The following is a description of a gene set: species: Mus musculus Genes predicted to be targets of miRBase v22 microRNA mmu_miR_6951_3p in miRDB v6.0 with MirTarget v4 prediction scores > 80 (high confidence targets). Mouse Gene Set: MIR_6951_3P from publication Chen Y, Wang X (PMID 31504780), and this is the list of marker genes: Syndig1l, Ythdf2, Kcnf1, Samd4, Mtss1, Cmtm5, Mark2, Tdrd3, Gab2, Bdnf, Galnt1, Angptl1, Rgs5, Pnma2, Sh3bp5, Pde4b, Mcc, Mllt3, Stxbp5l, Csgalnact2, Polr1g, Tmem39b, Slitrk1, Gtf2a1, Nrip3, Ccne2, Gnb4, Irx5, Ing1, Tab3, Bcl11b, Stc1, Zcchc14, Golm1, Tmem236, Kdm2b, Hipk2, Borcs7, Hnrnph2, Smarca2, Nup98, Rps6ka2, Dusp23, Zfp62, Spata2, Gm10377, Rhobtb3, Foxp1, Mesd, Grin3a, Fbxo28, Agfg2, Fbxw2 (NCBI Gene Id 77009), Mctp2, Tapbpl, Rbfox3, Tram1, Rs1, Lrit2, Glcci1, Chd8, Gnao1 (NCBI Gene Id 14681), Rep15, Ccbe1, Hmgxb4, Harbi1, Nr4a2, Utp25, Rbm11, Ddx3x, Mospd1, Zeb2, Ppp4r3b, Btbd9, Rab7b, Srcap, Ranbp3l, Rbpms, Mtf2, Efnb1, Zcchc3, Krr1, Arhgap32, Gpc3, Ncf1, Wipf2, Prkce, Taf1, Pi15, Rufy2, Zfp626, Snap91, D930020B18Rik, Zfp945, Eps8, Fam217b, Nras, Igsf3, Ssb, Phip, Gnrhr, Gspt1, Igf1, Mastl, Scn8a, Zfp1, Reln, Nsd3, Bicral, Gm11544, Ier5l, Lyve1, Echdc1, Zfp605, Tceal9, Yae1d1, Phactr4, Hoxb9 (homeobox B9), Fen1, Ncam1, Tm9sf4, Dennd2d, Ikzf2, Foxn1, Pdcd10 (NCBI Gene Id 80414), Msx1, Ctbp2, Srsf10, Crtam, Cyp2c50, Xiap, Barhl2, Ctcfl, Pwwp2a, Tjp1, Pcdhb7, Ago4 (argonaute RISC catalytic subunit 4), Rfx7, Ppp1r9a, Faxc, Ralbp1, Usp45 (ubiquitin specific petidase 45), Nat8f7, Dennd1b, Nrg2, Alcam, Tnn, Lsm11, Fras1, Mitf, Rbm47 (NCBI Gene Id 338502), Lhfpl6, Fry, Pabpn1, Tlcd4, Inpp4b, Gpr85, Pax6, Slc1a2, Zbtb21, Dcdc2a, Trim2, Smurf2, Pcdh15, Fubp3, Rrp36, Hic2, Zfp994, Lamp5, Atp2b1, Pknox1, Ube2k, Gatc, Rflnb, Snap29, Ash1l, Mbnl3, Vdr, Msl1, Arhgap5, Gpr82 (G protein-coupled receptor 82), Arhgap15, Plet1, Celf6, Kcnd2, Shox2, Dpp9, Fgf7, Mgat4c, Gdi2, Wipf1, Entpd7, Chic1, Zfp263, Phactr3, Tmod1, Atxn1, Set, Klhl13 (NCBI Gene Id 67455), Asap2, Dipk1a, Mylip, Osbpl8, Atp2b4, Prkab2 (NCBI Gene Id 99943), Cd59a, Tmem45a, Mia3, Gabra4, Tnfaip8, Celf1, Il1rap, Cd84, Gdap1, Fhip2a, Jchain, Prps1l3, Efr3a, Zkscan8, Fam222b, H13, Zcchc18, Tiprl, Ubtd2, Pakap, Ndufa10, Lilra6, Pdxdc1, Bmp4, Pgap2, Csnk1e, Prickle2, Myo9a, Aldh8a1, Bmp2k, Alkbh7, Rapgef4 (Rap guanine nucleotide exchange factor (GEF) 4), Lipa, Zc3h11a (zinc finger CCCH type containing 11A), Dio2, P2ry10b, Adcy6 (adenylate cyclase 6), Xbp1, Muc20, Prr18, Ttll3, Maff, Pum1, Mfsd11, Cltrn, Lmo2, Tes, Ubxn2a (UBX domain protein 2A), D630003M21Rik, Crim1, Ttc23l, Ptp4a2, Anks1b, Dph6, Rtn1, Senp1, Zfr, Flrt3, Tmem161b, Prrx1 (paired related homeobox 1, NCBI Gene Id 98443), Rsf1, Slc45a4, Neu1, Pdk1, Adss2, AW209491, Mss51, Enox1, Pphln1, Tut4, Dnmt3b, Smu1, Nrap, Zbtb5, Kcnma1, Rragd, Atp2b2, Mbtd1, Myc, Sema3c, Serpinb1c, Sys1, Ston2, Zdhhc21, Cnot6l, Rassf5 (NCBI Gene Id 98602), Arap2, Nipal1, Dpf1, Gtf2ird1, Osbpl3, Ctdspl2, Hnrnpr, Hadh, Irx2, Tmem50b, Otud7b, Usp40, Rbms3, Ift122, Mnt, Limd1, Klhdc10, Cdkn2b, Adcy9, Csnk1g3, Fnta, Pm20d2 (peptidase M20 domain containing 2), Nuak2, Mmp8, Manea, Chd1, Tiam1, Lhx5, Gbp2b, Ttn, Vcp, Clstn3, Wac, Rc3h1, Dstyk, Kctd4, Dach2, Hoxc10, Fbxo33, Pcdh17, Col2a1, Bmt2, Cnot4 (CCR4-NOT transcription complex, subunit 4), Xkr4 (X-linked Kx blood group related 4), Camkk2, Fst, Snx18, Tet3, Prrc2b, Syne2, Pdzd8, Hoxb3, Tecpr1, Scube2, Pum2 (NCBI Gene Id 80913), Hcn1, Adam17, Zfp236, Zfp827, Pbx1, Gbp7 (guanylate binding protein 7), Aftph, Ptpdc1, Nfic, Fzd3 (NCBI Gene Id 320969), Trpc5, Krtap4-22 (keratin associated protein 4-22), Grm8, Irf8, Hrk, Nek7, Pter, Alg11, Raph1, Zfp148, Cadps, Arb2a, Sh3glb1, Prkacb, Map3k20, Apbb2, Nalcn, Jun, Trim33, Rorb, Notum, Eeig2, Rarb, Cobl, Tent5c, Strbp, Pik3c2a, Pbx3, Zbtb43, Oxct1 (NCBI Gene Id 67041), Kif3a, Bend7, Kdm6a, Id2, Nhlh2 (NCBI Gene Id 320182), Terf2, Wwp1, Ptma, Sox8 (SRY (sex determining region Y)-box 8), Mapk10, Ms4a4b, Naa35, Tpt1, Zfp120, Mapk1, Zfp772, Ppm1l, Syne1, Slc2a9, Nap1l5, Tmem234, Gabrb3, Scamp3, Prkar2b, Cdk14, Pja1, Cdh6, Sfrp1 (NCBI Gene Id 72362), Pgap1, Tspan15, Prkd3, Lzts2, Maml2, Syt7, Kdsr, Kif21a, Thsd7a (NCBI Gene Id 671480), Ppargc1b, Neurog1, Ddx6, Dera, Atg5, Haus2, Kansl1, Ifit1, N4bp1, Crtac1, B4galnt2, Steep1, Rbfox1, Esr2, Purb, Rbm27, Lrrc58, Marchf5, Slit2, Fstl5, Dusp3, Clasp1, Elavl4, Zmynd11, Tmem231 (NCBI Gene Id 234740), Klk9, Zfp65, Tfdp2, Setd7, Nsd1, Cmtm3, Zfp354c, Nrxn3, Celf2 (NCBI Gene Id 97032), Fgd1, Srgap1, Gap43, Oxt, C330018D20Rik, Cnih4, Pou3f4, Satb2, Selenos, Slc66a2, Sorbs1, Mccc2, Nefl, Lrp6, Tshz2, C1rl, Lhx2, Nelfa, Mpv17l, Meox2 (mesenchyme homeobox 2), Chrm3, Zc3h18, Yipf5, Dach1, Rnf169, Satb1, Milr1, Nfatc1, 6430548M08Rik, Cadm2, Pbdc1, Map1a, Homer1 (NCBI Gene Id 26556), Mga, Shoc2, Bicd1, Scn9a, Papola, Lpp, Oma1, Sfxn1, Lrrc4c, Etv1, Ccsap, Tmed5, Stap1, Hdgfl1, Spsb1, Mosmo, Cdc14a, Glg1, Greb1, Khdrbs1, Srek1, Fmo2 (flavin containing monooxygenase 2), Ttc23, Tomm40, Slc37a1, Pde7a, Dgkh, Adam28, Gng7, Lpar6, Pdcd6ip, Snx30, Nexmif, Nfyb, Chrdl1, Unc79, Sall3, Pdzd2, Sgip1, Srpk2, Ablim1, Ankrd10, Pax9, Neurod2, Vcf1, 1700129C05Rik, Tgfb2, Plin3, Adcyap1, Mmp12, Il6ra, Myo1b, Gm20736, Ypel2, Larp4, Pde8b (phosphodiesterase 8B), Il11, Pard3, Kcnh1, Taok1, Zfand5, Erich1, Lrrc17, Gda, Rad23a, Gphn, Serpine2, Plekha8, Sox21, Brcc3, Nsun6, Enpp2, Bfar, Taf3, Acp3, Mapre2, B4galt6, Pgm2l1, Grm1, Ets1, Rgs13, Grb14, Ctsc, Sspn, Gpx5 (glutathione peroxidase 5), Abcb1a, Dock4 (dedicator of cytokinesis 4), Eomes, Ifi202b, Rigi, Tmx4, Rnf167, Hadhb, Actr2, Steap2, Kcnk10 (NCBI Gene Id 77454), Apobec1, Exoc5, Mtcl3, Castor2, Marchf2, Ing2 (inhibitor of growth family, member 2), Wdsub1, Casp3, Ttc5 (tetratricopeptide repeat domain 5), Dhfr, Acsl6, Rps6kb1 (ribosomal protein S6 kinase, polypeptide 1), Plppr5, Grip1, Rangap1, Ube2h, Olfml2b, Gna11, Zfp937, Csmd1, Eva1a, Caap1, Hs2st1, Ptpn1, Acvr2b, Kcnk3 (NCBI Gene Id 16527), Cdk17, Ammecr1l, Triml1, Zfp385b, Cep15, Chd7, Adtrp, Ssh2, Cytip, Zfp616, Bclaf1, Gna13, Samsn1, Mtif3, Klc1, Hoxc13, Angel2, Nsg2, Cpm, Pou2f1, Ikzf5, Serbp1, Mxi1, Braf, Lhx6, Tmem127, Tmcc3 (NCBI Gene Id 97668), Col27a1, Chfr, Hexim1, Flt1, Gas2l3, Lmo4, Dnajb5, Pde6c, Ccnh, Aebp2, Itgb6, Maf, Phex, Bach2, Katnal1, Efna2, Bnip3l, B3galt1, Sertad2, Kcnh8, Lcor, Tfb2m, Stox2, Cenpm, Fbxo41, Plekhh3, Myo1c (NCBI Gene Id 97728), Rims2, Bend3, Tirap, Kcnb1, Dock9, P4ha1 (NCBI Gene Id 18451), Fam227a, Bag4, Jdp2, Cdc42, Pou3f1, Abl2, 1700001F09Rik, Dmrta2, Smc5, Heatr3, Ano6, Cemip2, Cacna1e, Npepps, Hycc1, Srpx, Col1a2 (NCBI Gene Id 12843), Rad51d, Dgkg, Tox, Pitx1, Mlxip, Apaf1, Sult1b1 (NCBI Gene Id 56362), Atg7, Cyfip1, Pds5b, Bicc1, Ppm1b, Fnip2, Tgm5, Ehf, Sox11, Nrxn1, Myh15, Cyfip2, Psmc6, Nyap2, Scn1a, Pou4f1, Lig4, Tardbp, Proser2, Slc25a39, Irf2, Asb7, Nudcd2, Cnot6, Camk4 (NCBI Gene Id 52876), Klhl31, Cul2, Hecw2, Ebf1, Smg1, Mical2, Lypd1, Aak1, Med1, Slc9a2, Foxred1, Fbxl17, Lrrn2, Slc16a12, Tmem132c, Glod4, Rbm46, Kcnc3, Camk2a, Nfasc, Kdm5a, Runx1 (runt related transcription factor 1), Prdm6, Sall4, Zmym2 (zinc finger, MYM-type 2), Nampt, Cpsf7, Hacd4, Prdm16, Meis2, Stt3b, Crebrf, Zdhhc20, Ndel1, Lpar1, Gclm (glutamate-cysteine ligase, modifier subunit), Fyttd1, Tmem19, Psmd11, Tle1, Tnip3, Ptprj, Rad54l, Kat6b, Tjp2, Ap5m1, Dlc1, Tmem132b, Mctp1, Nrk, Jph1, Macroh2a1, Fmn2 (formin 2), Mafb, Enpp6, Yod1, Tia1, Htr4, Armcx3, Gtf2h5, Fgd4 (NCBI Gene Id 320417), Rab6a, Tcaim, Nek1, Ophn1, Nfia, Trio, Teddm3, Tmem184c, Zfp442, Bmpr2, Lonrf3, Cybb, Kcnk1, Htr5b, Snx10, Gpc6, Zic4, Nppc, Zbtb14, Ptgs2, Spdya, Mycbp2, Snrk, Efcab12, Sfmbt1, Cdc25a, App, Cdh8, Gm10375, Dlk1, Jakmip2, Cbx5, Rnf170, Dhx32, Palld, Samd5 (NCBI Gene Id 320825), Rpgrip1, Pik3cg, Gata3, Hecw1, Drd5, Limd2, Fgl2, Slc5a12, Nipsnap2, Cmip, Asb10, Wnt5a (NCBI Gene Id 77565), Slc7a11, Sostdc1, Sec22c, Tcf21, Fgfr1, Nedd4l, Thg1l, Pias1, Spred2, Zfp141, Lrrc75b, Gtf2h1, Emx2, Pmepa1, Aga, Pkia, Rgs7, Efna5, Chd6, Far2, Tshz3, Rbm7, Celf5, Pld5, Rreb1, Zc3h12a, Tigd4, Phykpl, Trabd2b (NCBI Gene Id 666048), Nalf1, Map3k3, Bzw2, Nol4, Wdr89, Clpb, Drap1, Lmbrd1, Zfp36l1, Rabgap1l, Hbegf, Nbeal1, Trip4, Dcaf8l, Flrt2, Tent4b, Casd1, Slitrk4, Dapk1, Dcun1d1, Pgam5, Coq5, Smad6, Itpr2, Zfp811, Pdgfra, Ccnd2, Hoxd4, Cebpg, Hoxb1, Nit1, Rdh12, Ncor1, Hycc2, Mcmbp, Sema3d, Bicd2, Rora, Rbms1, Pcdh10, Cadm1, Phf20l1, Abca1, Dock1, Lamp2, Lrrc55, Tsn, Homer2, Cd47, Slc20a2, Tmem177, Rexo2, Sec23ip, Abcd2, Zfp329, Eln, Shisa9, Mpv17, Arhgef9, Setd1b, Socs3, Garem1, Slc8a1, Hopx, Gucy1a2, Dst, Dnajc3, Mau2, Acod1, Man2a1, Midn (midnolin), Ptchd4, Nlgn1, Wdr31, Grpr, Tenm3, Unc5d (NCBI Gene Id 320828), Ptpre, Cacna1c, Eef1e1, Dnm3, Lats1, Tram1l1, Chst11, Dnal1, Calm1, Dpm1, Tnrc6c, Erc2, Smpd3, Aggf1, Neto1, Mkrn1, Tmx3, Trmt1l, Rell1, Zpr1, Igf2bp2, Mfhas1, Csrnp3, Prkg1, Lrrc15, Cmah, Camk2g, Fndc3c1, Senp5, Akap1, Chst15, Narf, Rab3d, Nipbl, Zfp287, Plcd3, Syt4, D130043K22Rik, Mmrn2, Ankrd49, Prok2, Rab27a, Ltbp1, Nkain3, Nab1, Stat3, Creg2, Clip4 (CAP-GLY domain containing linker protein family, member 4), F2rl1, Gigyf1, Acvr2a, Tob2, Lima1, Ergic2, Isg15, Cdh2, Nsd2, Nav1, Mfap3l, Riox2, Ccdc38, Plxna2, Ipo9, Clock, Foxo1, Tmeff1, Sox6, Kras, Poc1b, Sphkap, Mideas, Cdkl1, Sypl1, Mtmr6, Ube2j1, Tmcc1, Klhl4, Gnaq, Ifitm10, Hdac7, G3bp2, Ubash3b, Rfx3, Hspa12a, Tmppe, Igsf9b, Gfra1, Aass, Kat6a, Rnf138, Zfp386, Frmd6, Csgalnact1, N6amt1, Lrrc10b, Cdc42ep3, Htr7, Nfkbia, Cd226 (CD226 antigen), Kcnc1, Coch, Syt11, Atxn2, Peli1, Spopl, Hpgds, Chsy3, Trdn, Gm128, Dars1, Wfdc21, St3gal2 (NCBI Gene Id 20444), Smarcc1, Lrrc2, Bub1, Bcl9l, Irak1, Septin3, Unc13a, Ldah, G6pc2, Epha4, Rhoh, Rab33b, Col4a4, Fli1, Rnf152, Stx16, B3gnt5, Dusp10, Arid1b, Cavin2, Mapk8, Tmf1, Tspyl5, Snw1, Wwtr1, Cask, Klk7, Rpe, Zfp267, Snhg11, Fam120c, Brpf1, Rufy3 (NCBI Gene Id 72186), Itih5, Rasgef1a, Pank1, Dcaf10 (DDB1 and CUL4 associated factor 10), Kif26a, Rbbp4 (retinoblastoma binding protein 4, chromatin remodeling factor), Actn1, Gm15455, Dscam, Tbc1d8b (TBC1 domain family, member 8B), Enah (ENAH actin regulator), Gdpgp1, Slc4a4, Mbnl2, Nat8f3, Myo5c, Nr2f1, Tmem108, Ermn, Lingo1, Slc16a2, Plxnd1, Baiap2, Exoc8, Pabpc4l, L1cam, Msantd2, Eri1, Zfpm2, Flrt1, Creb5, Rnf11, Pias4, Frmd3, Pten, Ripply3, Pip5k1b, Hdgfl3, Galnt13, Spry4, Bmp2, Cldnd1, Ppp2r5c, Esr1, Tgoln1, Slc17a6, Cysltr1, Apc, Tet1, Zbtb11, Cdk13, Cnih3, Rasa1, Lmo7, Sorcs2, Lcp1, Atg10, D16Ertd472e, Cdc14b, Scfd2, Mtpn, Amer2, Kdm6b, 2010106E10Rik, Itgb4, Odad2, Iqgap1, Nlk, Swt1, Dnaaf10, Igip, Dennd6a, Pitpnm3, Cd44, Slc7a3, Exosc2, Crispld1, Adgrg6, Nrp2, Col4a1, Unc5b, Zfp800, Golm2, Cdh11, Mrpl51, Znrf3, Ogdh, Lsamp, Irf2bp2, Kdm5b, Gja3, Zfp292, Fnip1, Cux1, Zpld1, Pard6g, Phactr1, Klf13, Tead1, Gpd2, Etf1, Pira2, Ccdc78, Col13a1, Tril, Socs2, Ilrun, Nek4, Slc22a15, Ryr2, Cd2ap, Mef2c, Tpbg, Setbp1, Klhl24, Or5m3b, Spata6l, Bmp5, Galnt2, Rpl37rt, Rasgrp4, Dag1, Stam, Zfp24, Osbp2, Dcaf12l1, Rpl32l, Cdc40, Hs3st3b1, Zeb1, Abi2, Asb4 (NCBI Gene Id 74523), Gatm, Ptbp3, Pcsk5, Fblim1, Chdh, Fezf2, Clcn4, Cxcl9, Ado, Ubr2, Ttc14, Ier3ip1, Fam204a, Sim1, Arl16, Mapt, Zfp395, Six3, Map2k3, Camk2n1, Tecpr2, Bnc2, Wdr36, Sema6a, Arx, Clcn3, Yeats2, Slc32a1, Timp2, Net1 (neuroepithelial cell transforming gene 1), Tent5a, Kctd12b, Phc3, Tmem167 (NCBI Gene Id 77129), Sh3rf2, Fbxo32, Osbpl6, Larp4b, Zfp592 (NCBI Gene Id 330576), Pax3 (NCBI Gene Id 18505), Mkrn3, Ccr2, Ifi209, Mfsd4a, Setdb1, Cyb5r2, Gse1, Fyn, Akap10, Zmiz1, Slc12a1, Ccni, Slx1b, Ark2c, Daxx, Fhip1b (FHF complex subunit HOOK interacting protein 1B), Ankrd33b (ankyrin repeat domain 33B), Kif2c, Zdhhc3, Nhsl2, Atp7a (ATPase, copper transporting, alpha polypeptide), Prpf19, Pak5, Ppp1r16b, Rbm8a, Cnksr2, Rhou, 6030458C11Rik, Adam34, Unc5c (unc-5 netrin receptor C), A130010J15Rik, Wdfy1, Med13l, Cmc2, Arxes1, Mtus2, Rnf216, Tshr, Zfp641, Nr2c1, Nr4a3, Tcf4, Acer3, Marchf7, Ptges3, Smad4, Dab1, Ctnnbip1, Ldlrad3, Bri3bp (NCBI Gene Id 76809), Hltf, Pdgfb, Nfib, Pik3r1, Klhl34, Zfp606, Usp3, Mef2d, Rapgef2, Dgkb, Pom121, Slc38a6, Specc1, Atosb, Lpar3, Fndc5, Olfm1, Far1, Fyco1, Alkbh8, Scamp2, Sox9, Taf4b, Vgll3, Adhfe1 (alcohol dehydrogenase, iron containing, 1), Tnpo3, Cbfa2t3, Cnr1, Gid4, Sel1l, Ccnjl, Uty, Baz2a, Mafg, Kmt5a, Snx16, Vldlr, Ywhaz, Cmtm4, Pls1, Rgs2, Nectin1, 2510009E07Rik, Cyp26b1, Zfp101, Vangl1 (NCBI Gene Id 229658), Sstr1, Stk4, Rnf168, Otc, Cebpz, Dmxl1, Klhl9, Bcl7a, Gab3, Atp6v0a2, Banp, Sesn3, Eif3a, Prmt5, Tmem164, Ctdspl, Aph1a, Ssbp3, Bpnt2, Asph (NCBI Gene Id 97379), Skor1, Smim10l1, Etv6, Smarce1 (NCBI Gene Id 74752), Egr3, Cpe, Ccdc50, Chn2 (chimerin 2), Cacna1g, Cabp4, Cdadc1, Camsap1, Phactr2 (phosphatase and actin regulator 2), Elp4, Styx, Orc4, Ldb1, Rai1, Dclre1c, Arhgap26, Zfp111, Apod, Adgrl1, Sox4, Mtrf1, Asxl2, Pcdh7, Acsl1, Kcnh3, A2ml1, 2900026A02Rik, Veph1, Ube2l3, Mprip, Cntn4, Dusp6, Hmgb1, Rnf144a, Dcn, Tmem47, Mef2a, Lax1 (NCBI Gene Id 240754), Enam, Tnni1, Tal1, Isg20, Vapa, Zfp281, Casz1, Lonrf1 (NCBI Gene Id 244421), E130308A19Rik, Sox5, Snx27, Atp8b4 (ATPase, class I, type 8B, member 4), Fuca1, Ppp1r3d, Lin7a, 2310030G06Rik, Col25a1, Klhl1, Mpped2, Unc13c, Fbln2, Pik3ca, Bace1, Trps1, Lrat, Vegfa, Klf9, Dusp18, Tex26, Zfp365, Slc30a4, Zfp322a, Thap1, Grm7, Cxxc4, Lrrc20, Ttc28, Mob3b, Lpl, Ube2o (ubiquitin-conjugating enzyme E2O), Frmd4a, Ncald, Sorbs2, Foxp2, Dtna, Camk1d, Sptbn1, Klhl40, Eif4g3, Phf21a, Slc18a2, Podn, Plcxd2, Rprd2, Cdh12, Nufip2, Ddx3y, Mcur1, Grap2, Rpl27, Alb, Tacc2, Wdr33, Spmip4 (NCBI Gene Id 70821), Nr3c1, Klf6, Wdr37, Tcf7l2, Dkc1, Rftn2, Mex3a, Kmt2c, Fmn1, Gm57848, Usp37, Bet1l, Arpc1b (actin related protein 2/3 complex, subunit 1B), Jkamp, Celsr2, Atmin, Pipox (pipecolic acid oxidase), Rgs17, Lin54, Fam177a, Kcnj15 (potassium inwardly-rectifying channel, subfamily J, member 15), Cdk7, Ptprb, Msrb3, Acvr1c, Zfp647, Npr3, Pde4a, G2e3, Edaradd, Plxna4, Jmjd1c, Bptf, Zfp78, Kdm2a (NCBI Gene Id 71431), Eid1, Aida, Wnt3, Matr3, Gpm6b, Pde6a, Tmcc2, Zfp503, Prap1, Rem1, Nus1, Npc1, Mthfd2l (NCBI Gene Id 68621), Dnmt3a, Ccdc121rt2, Fbn2 (NCBI Gene Id 407822), Vapb, Sp4, Atp2a2, Reep3, Asf1a, Zbtb20, Parva, Tm7sf3, Vrk1, B3glct, Nacc2, Opcml, Smpd4, Ncl, Ebf2, Jade1, St8sia1, Glul, Hs6st2, Tmem217, Abhd5, Rnf130, Glyr1, Wdfy3, Ern2, Btg2, Tnfaip1, Sass6, Terf1 (telomeric repeat binding factor 1), Cpeb1, Slc23a1, Hmx2, Frg2f1, Mbnl1, Crkl, Btrc, Usp34, Igf2bp3, Diaph1, Sdc2, Dusp22, Zcchc24, Kif23, Fign, Lrrtm3, Elfn1, Zmynd8, Myocd, Car10, Cacna1b, Chst1, Usp15, Odr4, Bex6, Tbc1d12, Dse (NCBI Gene Id 212898), Cldn18, Klf12, Basp1, Gria1, Npas3, Zfp445, Fgfr1op2, Rmi2, Runx1t1, Cacna2d1, Etv3, Dennd10, Abcd3, Pou2f2, Srcin1, Lztfl1, Gabra1, Ppara, Stk39, Dnaja2, Prkca, Ppp3ca, Sorcs1, Syt1, Rpp14, Deptor, Fcer2a, Spon1, Chst2 (carbohydrate sulfotransferase 2), Gclc, Agtpbp1, Spata31d1a, Ube2w, Tnfrsf1b, Stk3, Spc24, Dscaml1, Arid3a, Mettl2, Cdk8, Pdzrn4, Marchf11, Luc7l2 (NCBI Gene Id 75005), Pitx2, Pank3, Pate4, Pth1r, Camta1, Capzb, Ecpas, Cstf3, Slc10a7, Zfp462, Limch1, Crispld2, Aco2, Tmem237, Bcas1, Ears2, Slc7a1, Man1a, Mecp2, Fam199x, Actl6b, Fbxw7, Nsmce2, Mylk4, Creb1, Suz12, Ubn2, Zfp646, Ptprt, Ascl1, Atxn2l, Ckap4, Frrs1l, Ccdc88a, Gfm2, Npnt, Cxcr6, Zfp871, Pigc, Ppp1r7, Tmem245 (transmembrane protein 245), Slc39a8, Spock1, Gstt4, Ebf3, Cntnap2, Fxn, Amy2a3, Trim24, Prkcb, Cpeb4, Scaf11 (SR-related CTD-associated factor 11), Polr2b, Ankrd52, Lpin1, Otx2, Suclg2, Csmd2, Pgrmc1, Amy2a2, Tktl2, Zmym4, Shroom2, Smarca1, Plcd1, Dsg2, Caln1, Ncmap, Sorcs3, Ank3, Hoxa5, Btbd17, Arid4a, 5730455P16Rik, Fbxo46, Ednrb, Gys1, Arg1, Tenm4, Slc46a2, Prkcd, Drd1, Chrna9, Snx24, Dynlt1a, Arpc2, Cln5, Prkaa2, Galnt7, Klhl20, Plppr1, Gon7, Pi4ka, Ncoa7, Ddx52 (DExD box helicase 52), Xrn1, Nipa2, Zfp516, Tcf7l1, Nrn1, Ogfrl1, Edem3, Arl4c, Egr1, Ptprs, Samd8, Pde1c, Wdr26, Atp6v1a, Rcn2, Slc17a5, Zc3hav1l, Ptprr, Ccnd1, Vsig1, Iho1, Magi1, Tshz1, Pip5k1a, Celf4, Tmem69, Icos, Tceanc2, Elavl2, Gria2, Garre1, Tmem169, Impg2, Frem2, Cdyl2, Usp2, Rab3c, Naaladl2, Ccnl1, Fstl3, Myt1l, Rnf128, Ubxn7, Btg1, 4921524J17Rik, Bean1, Pclo, Sppl2a, Fam76a, Cpeb3, Prkx, Vcpip1, Abhd6, Fsd1l, Exoc3, Itga6, Cdh13, Pkn2 (NCBI Gene Id 99668), Kif1b, Dclk3, Ppp2r2d, Camk2b, Gmeb1, Nfatc3, Ksr1, Ank1, Ccr1, Decr2, Ints9, Maml3, Tmod2, Onecut2, Pappa, Pgr, Zfp131, Sertad4, Ehmt1, Taok3, Eci1, Rab27b, Atxn7l2 (ataxin 7-like 2), Mak, Fgf12, Stxbp5, Pcdh9, Cap2, Tsc22d2, Agap1, Oosp2, Epn2, Man1a2, Psmd14, Ssbp2, Adgrl2, Pcnx1 (NCBI Gene Id 80635), Nadk2, G3bp1, Ctnnd2, Xaf1, Slc12a2, Arhgap17, Cacnb4, Mdga2, Stag2, Nwd2, Slc10a3, Dcx, Nfix, Appbp2, Tfap2a, Adora1, Glrx2, Qki, Mtf1, Ctxn3, Synj1, Retreg1, Herpud2, Tafa1, Cbln2, Prr5l, Adamts5, Fam168a, Map3k1, Smg8, Ar, Map2, Rasgrp3, Inhbb, Senp7, Atp8a1, Pias3, Brd3, Prkg2, Ism1, Lrrc39 (NCBI Gene Id 77307), Igf2bp1 (NCBI Gene Id 98709), Zfp950, Rock2, Kdm7a, Tafa2, Tbx3, Myct1, Dnajb6, Nrp1, Arl6ip1, Txlng, Fgf18, Pdik1l, Psma3, Gpr137c, Hdac9, Ints2, Sfmbt2, Mier3, Rbfox2, Kif14, Sp1, Fga, Cmtr2, Cgas, Mkrn2os, Csde1, Hsdl1, Dclk1, Mfap3 (NCBI Gene Id 76818), Ep300, Tmpo, Otud1, Mob4, Acot2 (acyl-CoA thioesterase 2), Ntm (neurotrimin), Ptchd1, Tacc1, Lrrc49, Vamp5, Dlgap1, Scml4, Tbx5, Ntrk2, Ppp4c, Rnf6, Znrf1, Psd3, Fktn, Ahdc1, Pak3, Cxadr, Rhobtb1, Mfsd6, Hyal3, Rtn4rl1, Jund, Matn4, Pcbp2, Nr6a1, Thrb, Dlgap4, Hoxb4, Zfp830 (zinc finger protein 830), Frrs1, Strn3, Rapgef6, Nudt16, Jak1, Plekha2, Grb2, Stx3, Opa3, Dcaf6, Csnk1g2, Marcks, Ephx4, Pcdh19, Lig3, Csnk1a1, Gpr12, Zc3h12c, Tnpo2, Gpatch8, Skil (NCBI Gene Id 71615), Gpr83, Cdc37l1, Parp3, Mettl16, Tmeff2, Rab11b, Itm2c, Cbll1, Slc16a9, Nr5a2, Ifi205, Foxq1, Cramp1, Tulp4, Magt1, Clmn, Fndc3b, Fbxo5, Zfp617, Ttf1, Abcd4, Procr, Glud1, Rsad2, Pde10a, Kin, Hikeshi, Hmgcll1, Lta4h, Prkn, Bdp1, Magohb, Gpatch2, Pabpc2, Vezt, Fut9 (NCBI Gene Id 14348), Adam20 (a disintegrin and metallopeptidase domain 20), Zswim6, Rasa2, Fbxl3, Gsk3b, Pbxip1, Stimate, Tm4sf20, Sulf2, Col19a1, Lrrc8e (NCBI Gene Id 97482), Ptprz1, Qrfp, Rc3h2, Irf1, Daam1, Bcl2, Mtif2, Gria3